Given this list of marker genes SP100, KDM3A, UGT2B11, CEP350, ATP6V1G2, LBH (LBH regulator of WNT signaling pathway), GAPVD1, RUFY1, RNMT, FANCD2OS, MAP2K1, ZNF468, RORB, PCDH19, ACOX1, STARD7, CIR1, HEATR5A, NUP50, JPT1, IRS1, USP13, DNAJC6, ABCA1, AKIRIN1, ERBB3, LINC00390, AGO2, GTPBP10, PTGDR, ARIH1, ITGA1, LAMB4, DIRAS1, FAM118A, PLCG2, RGL2, LCOR, SLX4IP, FRYL, DTX4, DBF4B, MAP3K20, CBFA2T3, FBLN7, MAGI3, NECAP1, STIMATE, GPRIN3, CASD1, ECE2, MAN1A1, SH3BGRL2, SLC35F5, SH3GL3, ADRB1 (adrenoceptor beta 1), CSDC2, SMAD1, HABP4, FGF14, PLAG1, TSHR, NAV2, NRXN3, PITPNM3, TMX3, RAB10, LIPA, NAA50, SCYL2, AGFG1 (NCBI Gene Id 3267), ZNF28, DTD1, ZNF816, UGT2B10, BAG4, CTSV, ARL5B (ADP ribosylation factor like GTPase 5B), SZRD1, SPIN4, TDRD5, DUSP2, ZFP36L2, DCUN1D5, CSTF2, ZMPSTE24, PLPP3, HOXC6, CTXN2, HS6ST3, ENOX1, NEURL1B, TNRC6A, TNRC6B, COLQ, BEND4, GABPA, TMTC3, UBE2V1, G3BP2, SRP9, GATD3, SELENOS, XPR1, STRADB, GOSR2, SH3BP5, UBE2J1, HDAC9, PPME1, CAMTA1 (calmodulin binding transcription activator 1), TET1, EMP1, TMEM181, ZFP36L1, STT3B, PTAFR, SASH3, PCSK2, TREML1, SNTG1, SLC7A11, ZFP1, CYP4A22, CNTN1, PRDM16, DEFB134, TIAL1, IFI44L, ATP13A4, RASGEF1A, PHAF1, GATA6 (GATA binding protein 6), USP6NL, TMEM184B, ANK1, PRDM10, KDM7A, ZBTB46, SCN1A, HECA, INO80D, SLC39A10, SYBU, PET117, CLEC12B, DCLK1, MAP4K3, PANX1, ARHGAP36, PIANP, INPP5J, HSPD1, CAB39, FOXP2 (forkhead box P2), SLC10A7, KCNH1, TADA1, SNX15, BEND7, GNG2, ZDHHC7, KMO, LARP1, ARL8B, TCF12, TREML4, RIMS2, NIPSNAP2, ACVR2B, RNF220, ARK2N, NFE2L1, FIGN, SNAP25, ZNF432, ADO, MAP1B, PRDM11, NUFIP2, AGRN, PDE5A, AMOTL1, HIPK2, ZFX, CCDC28B (NCBI Gene Id 79140), TSLP, THUMPD1, WEE1, KIAA0040, TMEM38B, TOMM6, RAB33B, ACP3, CTBP2, EYA4, ZNF117 (zinc finger protein 117), TENT2, NCK1, CCK, CDH24, LPIN2, NRK, HDGFL3, GRIN2D, CHN2, PBX1, ATXN1, MLLT10, MARCHF10, NFIB, SYNRG, ZNF486, DDX6, CRISP1, here is a description of the gene set: Human Gene Set: MIR12122 Genes predicted to be targets of miRBase v22 microRNA hsa-miR-12122 in miRDB v6.0 with MirTarget v4 prediction scores > 80 (high confidence targets). from publication Chen Y, Wang X (PMID 31504780) studied in species Homo sapiens